Given this list of marker genes FOXP2, INMT, ZBTB37, SLC10A7, STX5, LNPK, TOB1, NTRK3, NSG2, TBCC, LASP1, PPP2R2B, SCAMP1, POU2F1, FLRT3, ZMYND8 (NCBI Gene Id 55497), OPA3, RUNX1, NR2F1, KCTD12, PRKAG1, POU3F2, GDPD3, HCAR3, ZBTB22, YES1, HOXA10, SLC39A8, HR, NOSTRIN (NCBI Gene Id 115677), CDAN1, BRIP1, FOXD3, PPP1CB, HOXB9, MCTS1, FOXN3, IRS4, TCF7L2 (transcription factor 7 like 2), SUMO1, HMGN3, ZFYVE1, CREBRF, NR4A2, KRT84, CBX6, PAIP2, CLN5, PRIMA1, GOLGA1, COL13A1, ASPA, PDLIM3, ARHGAP30, SUPT4H1, MAPK10, PELI2, RASD1, ID2, ATXN7L2, KLF12, DUSP1, NR6A1, ASIC2, KCTD15 (NCBI Gene Id 79047), LTA, CRH, IL1RL1, LCP2, DTNA, CYP26B1, HOXB7, BRCA2, BUB3, LBX1, TSPYL2, OTX2, RABL6, C12orf57, KLF3-AS1, WNT2, MXRA8, ANKRD28 (ankyrin repeat domain 28), LYPD1, ELF1 (NCBI Gene Id 1997), UBE2H, HESX1, NECAB3 (N-terminal EF-hand calcium binding protein 3), USP3, SIM1, CREB5, MESP1, FSTL1, ARTN, ATP1B4, ARFGEF1, CXXC5, NEUROD2, RRP36, NSD3, ADGRB3, HMCN1 (NCBI Gene Id 83872), CXCL2, GRM3, LINC00649, ETV5, RAD21, IFNA17, ETV1, TGIF1, BAMBI, CPEB4, KIF21A, EMX2, ASXL1, SH3BGRL3, SOX2, IL25, IP6K2, SLC35D1, MARCKS, SLIT3, PURA, RBFOX1, KCNA4, TSPYL4, WBP1L, TFAP4 (NCBI Gene Id 7023), IFNA10, STARD13, MGLL, RPS6KB1, POGZ, CLDN8, INHBA, FLI1, PPARGC1A, TNF, TSPAN17, FRMD4A, CTDSPL2, TNR, NFIB, DPP10, GFRA1, CADM1, TSHZ2, BCLAF3, NIN (NCBI Gene Id 57681), CELF4, BEX2, MRI1, ESRRG, NR4A1, ITPKB, NEDD4, GPR142, XPO7, EGR2, ZBTB18 (NCBI Gene Id 10472), KCNQ5, PMCH, HOXA11, ENPEP, SYT6, NOVA1, RORA, GTF2A1, SCNN1G, PRR34, SNCAIP, ING3, IMPDH2, CACNG2, PARP8, C1QTNF3, MASP1, RTL9, ACP6, GPR18, C7orf33, AP1G2, BCL11B, DMD, WWC2-AS2 (WWC2 antisense RNA 2), ABCA1, REEP4, SMAD1, KLF3, NTF3, HOXC4, ORC4, SLC16A6 (solute carrier family 16 member 6), HCAR2, CCND1, SLC35C2, HAND2, IBSP, SNCB, SCG3, ZKSCAN5, ATOH8, RFTN2, FHL2, SSH3, FBXO11, CHD1, LMO4, here is a description of the gene set: Genes having at least one occurrence of the motif NNNTGTTTATNTR in the regions spanning 4 kb centered on their transcription starting sites. This matches the FOXJ1 transcription factor binding site V$HFH8_01 (v7.4 TRANSFAC). studied in species Homo sapiens Human Gene Set: HFH8_01